The following is a description of a gene set: Human Gene Set: KEGG_MEDICUS_PATHOGEN_HCMV_US28_TO_GNB_G_PI3K_NFKB_SIGNALING_PATHWAY HCMV US28 to GNB/G-PI3K-NFKB signaling pathway. Pathway ID: N00400. Pathway type: Pathogen. Pathway class: nt06167 Human cytomegalovirus (HCMV). species: Homo sapiens Pathway Definition from KEGG: US28 -> GNB/G -> PI3K -> PIP3 -> AKT -> IKK -> NFKBIA -> NFKB => (IL6,CXCL8), and this is the list of marker genes: GNB4 (NCBI Gene Id 59345), IKBKG, IL6, NFKBIA, PIK3CD, PIK3CB, GNG2, GNG11, GNG8, GNGT1, AKT3, GNB3, GNG10, CHUK, GNG7, GNGT2, PIK3CA, AKT1, GNB2, NFKB1, AKT2, GNG12, GNG3, GNG13, GNG5, CXCL8, RELA, GNB1, IKBKB (NCBI Gene Id 3551), GNG4 (NCBI Gene Id 2786), GNB5